Given this list of marker genes Vamp8, H2-M2, Psmb10, Psma1, H2-M10.2, H2-M10.6, Psmb8, Psme2, Psma6, B2m, Psma3, Psmb7, Psmb9, H2-M10.1, Psma5, Psmb6 (NCBI Gene Id 19175), H2-Q7, Psme1, Psma2, H2-M9, Psma4, Psma7, Psmb4, H2-Q10, H2-M3, here is a description of the gene set: species: Mus musculus This event has been computationally inferred from an event that has been demonstrated in another species.<p>The inference is based on the homology mapping from PANTHER. Briefly, reactions for which all involved PhysicalEntities (in input, output and catalyst) have a mapped orthologue/paralogue (for complexes at least 75% of components must have a mapping) are inferred to the other species. Reactome Pathway: ER-Phagosome pathway electronically inferred by orthology from the curated human pathway part of: Antigen processing-Cross presentation